Given this list of marker genes Ndufaf7, Fbll1, Carm1, Prmt1 (protein arginine N-methyltransferase 1), Prmt8, Prmt5, Fbl, Prmt2, N6amt1, Prmt6, Hemk1, Prmt9, here is a description of the gene set: Catalysis of the reaction: L-glutaminyl- + S-adenosyl-L-methionine = N(5)-methyl-L-glutaminyl- + S-adenosyl-L-homocysteine + H+. species: Mus musculus Mouse Gene Set: GOMF_PROTEIN_GLUTAMINE_N_METHYLTRANSFERASE_ACTIVITY